Given this list of marker genes GDF5, BMP4, LTBP2, FBN2, BMP10, EFEMP1, TGFB3, LTBP3, ITGA8, ITGB8, ITGB6, FBLN5, EMILIN1, FBN3, TGFB1, EMILIN3, ELN, ITGB1, FN1, VTN, LTBP1, MFAP4, FBLN2, ITGB5, EMILIN2, ITGAV, MFAP3, FBLN1, FBN1, BMP2, BMP7, TGFB2 (NCBI Gene Id 7042), EFEMP2, MFAP5, MFAP2 (NCBI Gene Id 4237), ITGB3, LTBP4, here is a description of the gene set: Human Gene Set: REACTOME_MOLECULES_ASSOCIATED_WITH_ELASTIC_FIBRES Molecules associated with elastic fibres studied in species Homo sapiens